Given this list of marker genes ITFG2, ACAT2, RANGRF, IRF2BP1, EDF1, ARHGAP1, RGS4, RGL2, TMEM212, RNASEH2A, RNF39, KLHDC2, FTO, MYO9B, GRAP, SLC4A4, ZNF589, CDC25B, OXA1L, CHKB, KYAT1, CANX, DOCK2, ADD1, PYY2, LAGE3, POLR2J, GLS2, ACTA2, SSH3, GPX4, TAL1, TNNI1, APBB3, ESYT1, PRSS16, GLRX5, TOM1, TROAP, PTTG1, NDRG3 (NDRG family member 3), TRDN (NCBI Gene Id 10345), ANKRD28, EXOC3, KHDRBS2, MAST3 (microtubule associated serine/threonine kinase 3), MYH10, KCNJ9, SLC2A4RG, RPL27, PRDX2, NPRL2, CRYBB2, TMA7, R3HDM4, SEMA4C, ATP8B3, HABP4, SPPL2B, CDCA3, FHL1, KLK1, NCK2, DHRS3, CNN2, NUP210, SLC17A4, RPL13, DBNDD1, MKNK2, NME7, TFPI2, VAT1, CEACAM8, NF2, CDC20, DCAF8, CPVL, LASP1, MXD3, CYTH4, ARRB1, NHERF1, GCHFR, PFDN5, FGR, UBASH3A, REG3A, SLC35E2B, CIDEC, ANAPC15, ECHDC2, RNPEP, CSTPP1, CERK, RAB33A, EFNB1, IMPDH2, FABP2, TMEM131L, PTPN3, SHC3, MAP1LC3B, LAPTM5, VPS52, NENF (neudesin neurotrophic factor), IGHMBP2 (immunoglobulin mu DNA binding protein 2), RHOF, ATP5ME, KLHL29, NPHS2, PLCG1, IQCA1, PTTG3P, RAB11FIP3 (NCBI Gene Id 9727), TEDC2, PIP4K2A, ZNF318, TP53I11, GATD3, SEC14L1, CBX7 (NCBI Gene Id 23492), NAB2, ATG14, PPP6C, DBN1 (NCBI Gene Id 1627), WASHC3 (WASH complex subunit 3), PPP2R5D, RIPK4, CYP2B6, PCSK7, GIPC1, SPSB3, HDAC3, ETHE1, ZNF512B, UNC119B, CORO7, GPR135, NR2F1, ANGPTL2, CDCA8, FLII, KRT10, H4C11, IFT52, SMPD1, TMC6, EGR4, B3GNTL1, CDKN3, LPXN, RBM23, LUC7L, CFAP74, TES, ERCC2, CD53, NUMA1, UBE4B, COTL1, PHF1, NCR3, RNF44, CROCCP3, ETFB, IRX5, AKR1A1, FKBP2, GMFG, MACROH2A1, SPON2, APOBEC2, KLHL35, USB1, NCAPD3, CCNB2, CDC25C, FUT2, NUAK1, GLYR1, SPCS3, APBA2, WAS, EEIG1, ADORA2B, RPL10, PRKCA, PRKCH, PACS2, PNN, PNRC1, ELK1, GULP1, PPM1F, SPINK4, NUDT7, UBE2C, CCNI, TAFAZZIN, here is a description of the gene set: The transcriptome of naive OT-I T cells was compared to memory CD8 T cells after 1, 2, 3, or 4 infection with ovalbumin expressing Listeria monocytogenes (LM-OVA). Genes down-regulated in CD8 T cells: naïve versus 3' memory. from publication Wirth TC, Xue HH, Rai D, Sabel JT, Bair T, Harty JT, Badovinac VP (PMID 20619696) species: Homo sapiens Human Gene Set: GSE21360_NAIVE_VS_TERTIARY_MEMORY_CD8_TCELL_DN